The following is a description of a gene set: Mouse Gene Set: GOBP_REGULATION_OF_INTESTINAL_ABSORPTION Any process that modulates the frequency, rate or extent of intestinal absorption. species: Mus musculus, and this is the list of marker genes: Apoa1, Enpp7, Lep, Isx, Cldn2 (claudin 2), Apoa4, Hamp2, Hamp, Apoa2, Abcg8, Cldn15, Lpcat3, Acat2, Prap1, Abcg5, Dgat1, Abcb1a, Cyp8b1, Epb41, Abcg2